The following is a description of a gene set: Human Gene Set: TTTGCAC_MIR19A_MIR19B studied in species Homo sapiens Genes having at least one occurence of the motif TTTGCAC in their 3' untranslated region. The motif represents putative target (that is, seed match) of human mature miRNAs hsa-miR-19a and hsa-miR-19b (v7.1 miRBase)., and this is the list of marker genes: CLIP4, ARRDC3, SNIP1, RAP1A, VPS37A, KIAA1217, MAP3K12, TP53INP1, RAB8B, PPP6R2, PLAA, PMEPA1, STAT5B, NHS, DOCK3, NR4A2, ABCB7 (NCBI Gene Id 8252), ETV1, SLMAP, RAB18, SUZ12, TRIM33, PCDHA7, CEP192 (centrosomal protein 192), SPIRE1, CGN, ELOVL5, BTBD7, KCNS2, MYCL (NCBI Gene Id 4610, MYCL proto-oncogene, bHLH transcription factor), DLX3, LIF, SYBU, ACSL4, CCNL1, TENT5B, SPHK2, CLOCK, CS, PIK3R3, B4GALT5, GRSF1, ENPP5, SHANK2, UCP3, RNF2, VCPIP1, ACBD5, ATXN1, ZFYVE26, ADCY9, FMR1, BTF3L4, ANKRD12, SV2A, NPAS2, TMEM63B, ADCY7, FLNC, COL19A1, ZNF800 (zinc finger protein 800), SLC48A1, NAV3, AFF1, CD69, MIB1, MON2, KCNJ2, ATP6V1B2, SKIDA1, CEP170, BAMBI, AKAP1, ARPP19, TENT5C, SLC9A2, TTYH3, SMAD5, NSD3, MED13L (mediator complex subunit 13L), CAMSAP1, PHLDA3, PCDHA2, KLHL20, MAP3K14, LRCH2, IGF1, CCM2, CDK19, EDARADD, ZMYND11, GDA, PPP6R1, CLTC, DHX40, RXRA, ADNP, BACE1, DCBLD2, SPTSSA, RAB33B, C3orf70, BNC2, ELL2, ATG16L1, PHTF2, FEM1C, EFNB2, SLC9A6, MACIR, TGFBR2, ATP10A, PRRC2C, DSEL, PTP4A1, ATP11A, TSHZ3, PARM1, CBX1, BMPR2, AGO1, HNRNPU, EVI5L, DTNA, REEP3, ATP2B2, SAMTOR (S-adenosylmethionine sensor upstream of mTORC1), TLN2, ARIH2, ARMC8, FNDC3A, TRPS1, SOX4, GPR137B, STK35, PCDHA10, WDR47, RBMS3 (RNA binding motif single stranded interacting protein 3), CBLN2, ST8SIA4, QKI, PEX5L, MIER1, DAG1, RAPGEF4, PCDH10, HECW2, ST8SIA3, CACNA1C, ITGA6, CDK13, MLLT6, HNRNPF, ASAP2 (ArfGAP with SH3 domain, ankyrin repeat and PH domain 2), MOSMO, LNPEP, PCDHA11, EXOC5, SYT1, KDM2A, TNFRSF12A, SEPTIN7, OCRL, ARHGAP5, MEF2D, GULP1, RGL1, DBN1, RNF111, PCDHAC2, ZNF711, IMPDH1, YTHDF2, MEMO1, CPEB4, CNOT6, NEUROD1, ASXL2, DLC1, MPHOSPH9, PAK6, HIPK1, DDX3X, LIMD2, PRICKLE2 (prickle planar cell polarity protein 2), NBEA, CHST1, HLF, MBNL1, RUNX2, GRIN2A, BCL3, PSAP, NRBF2, PTPRG, WBP1L, SNPH, KBTBD8, SFMBT1, LRIG1, ELMOD2, RAI2, BTG1, SOX6, ANXA7, RAB5B, ANO3, TNRC6A, SCARF1, BLCAP, SMOC1, SOCS1, TSPOAP1, FBXO28, CSMD1, TOGARAM1, F3, BSN, RASSF1, HDAC4, SRGAP3, FAM234A, CC2D1A, SGK1, ST3GAL5, PFN1, IVNS1ABP, ROBO2, NME7, PLXNC1, KIF3A (NCBI Gene Id 11127), MBD6, CNOT4, ZNF217, TXNDC12, LPP, NPTN, GPCPD1, PNRC1, RAPGEFL1, WBP2, FOXP1, RBMS1, ATP2C1, CCNT2, RAP1B, DENND1A, PRUNE2, ZNF609, ARHGEF12, ARFGEF1, PCDHA1, USP6, PATL1, CALM1, MB21D2, SULF1, CSNK1G1, FASTK, DNAJB1, RAB21, RNF38, FOXF2, VPS37B, ADAM12, VPS4B, USP32, PHF12, RIN2, POU4F1, CAB39, KIT, PCDHA12, KHDC4, LCLAT1, DICER1, NAPB, ARGLU1, ABCA1, CHMP4B, TGM3, PCDHA8, RFX1, RTN1, TGIF1, SOCS3, PTK2B, TOR1B (torsin family 1 member B), SEMA4C, PPTC7, MBNL2, NRP2, MFSD6, ELAVL1, ERBB4, CEP350, NIPA1, ITSN1, FZD8, ZDHHC7, CAST, WDFY3, KCNA4, RUNX3, SMARCD2, SHTN1, WNT1 (Wnt family member 1), NDFIP2, UBL3, PHF13, TBC1D8, MYCN, UBE2D2, DPYSL5, HBP1, MLEC, TNRC6B (NCBI Gene Id 23112), LRRK1, GJA1, MDFIC, MAPK14, ZDHHC18, SLC35F1, L3MBTL3, SPRYD3, INHBB, RIMKLA, MIER3, PLCB1, MAGI2, DDX6, PCDHA5, LRP2, ZEB2, PDE5A, POU3F2, FBXO8, FAM114A1, WDR45B, DNAJA2, RNF11, CAMTA1, MAPK6, ZBTB18, CREBL2, TNPO2, ITPR1, SLAIN1, TNIP1, ESR1, NPEPL1, SLC31A2, ZFYVE9, TGOLN2, PRC1, RFX4, RHEBL1, ID2B, PPARA, ZBTB4, MINK1, CLIP1, ATL2, LONRF1, TBK1, CREBRF, ARHGAP12, TSC1, ARK2C, PKNOX1, MID1IP1, IGSF3, WDR44, IGFBP3 (insulin like growth factor binding protein 3), TESK2, PHAF1, ARC, WEE1, PHF20, TENT2, PGM2L1, LBH, OGT, RBBP8, APPL1, TAF4, SNX17, ZBTB10, RAB34, PITX1, RHOB, SMARCA2, PRRT3, ADCY1, MYLIP, NRK, ZFP91, SLC26A7, DNAJC16, SLC24A4, WNT3, KLF13, CCDC126, EPC2, RALGPS1, RAP2C, GSKIP, ARHGAP21 (NCBI Gene Id 57584), B3GALNT2, EPHB3, PDE7B, CCDC88A, ARRDC4, KPNA4, AP1G1, G3BP2, NCALD, NOCT, STK38, ARFIP1, ELK3, CCSER2, RELCH, CNTFR, ABR, GRK6, MMGT1, PRR5L, SLC6A8, SPART (spartin), SOX21, SLC9A1, WDR1, MED26, ID4 (inhibitor of DNA binding 4), RAB2B, EPS15, ESRP2, EREG, MIGA2, EMX2, CCND2, BPTF, ATRX, IGF2R, SLC24A3, VGLL4, ZNF3, RAF1, CBFB, MECP2, ADAMTS18, CCN2, E2F8, LIN9, CNOT7, RNF145, PSD, ZFPM2, TRAK2, PLPPR1, KPNA3, ANO1, SBF2, BTAF1, SNX27, ADSS2 (adenylosuccinate synthase 2), PCDHA3, CBX7, WDR26, JAKMIP1, FAM43A, SOX5, CADM4, LSM12 (NCBI Gene Id 124801), KLF10, PITPNM2, DENND6A, MPPED2 (NCBI Gene Id 744), CYLD, PCDHAC1, ACTN1, USP33, PCDHA4, UBE2A, GET3, EPN2, ADIPOR2, BRWD1, SPEN, SPATA2, S1PR1, PCDHA6, GRM7, SDC1, SOCS5, DDX3Y, INO80, SYT11, PCDHA13, SMOC2, OLFM1, MED12L, ARID4B, MCRIP2 (NCBI Gene Id 84331), SH3D19, PCDHA9, WDR20, C2orf42, SRSF6, PPP2R5E, ARHGAP1, USP32P2, MACF1, ZNF518A, ATG14 (autophagy related 14), PFKFB3